The following is a description of a gene set: Dual Incision in GG-NER studied in species Homo sapiens Human Gene Set: REACTOME_DUAL_INCISION_IN_GG_NER, and this is the list of marker genes: POLE, GTF2H3, ERCC1, RPA3, PARP1, POLK, UBC, ERCC5, RPS27A, CHD1L, PARP2, POLD4, PCNA, RFC5, POLE3, POLD1, RFC3, POLE2, RBX1, RPA2, RFC1, POLD3, GTF2H4, ERCC3, GTF2H1, UBB, UBA52, POLD2, RFC4, CUL4A, GTF2H5, ERCC2, XPA, GTF2H2, DDB1 (NCBI Gene Id 1642), DDB2, ERCC4, RPA1, RFC2, POLE4, CUL4B